Given this list of marker genes CPT2, FGF21, EHHADH, HSD17B4, DECR1, ETFDH, G0S2, ACOT8, ACADM, HMGCS2, DECR2, ALDH3A2, ECI1, CPT1B, CD36, here is a description of the gene set: Hepatic genes regulated by fasting or in response to WY14643 and which require intact PPARA. Human Gene Set: SANDERSON_PPARA_TARGETS studied in species Mus musculus Peroxisome proliferator-activated receptor alpha (PPARalpha) is an important transcription factor in liver that can be activated physiologically by fasting or pharmacologically by using high-affinity synthetic agonists. Here we initially set out to elucidate the similarities in gene induction between Wy14643 and fasting. Numerous genes were commonly regulated in liver between the two treatments, including many classical PPARalpha target genes, such as Aldh3a2 and Cpt2. Remarkably, several genes induced by Wy14643 were upregulated by fasting independently of PPARalpha, including Lpin2 and St3gal5, suggesting involvement of another transcription factor. Using chromatin immunoprecipitation, Lpin2 and St3gal5 were shown to be direct targets of PPARbeta/delta during fasting, whereas Aldh3a2 and Cpt2 were exclusive targets of PPARalpha. Binding of PPARbeta/delta to the Lpin2 and St3gal5 genes followed the plasma free fatty acid (FFA) concentration, consistent with activation of PPARbeta/delta by plasma FFAs. Subsequent experiments using transgenic and knockout mice for Angptl4, a potent stimulant of adipose tissue lipolysis, confirmed the stimulatory effect of plasma FFAs on Lpin2 and St3gal5 expression levels via PPARbeta/delta. In contrast, the data did not support activation of PPARalpha by plasma FFAs. The results identify Lpin2 and St3gal5 as novel PPARbeta/delta target genes and show that upregulation of gene expression by PPARbeta/delta is sensitive to plasma FFA levels. In contrast, this is not the case for PPARalpha, revealing a novel mechanism for functional differentiation between PPARs. from publication Sanderson LM, Degenhardt T, Koppen A, Kalkhoven E, Desvergne B, Müller M, Kersten S (PMID 19805517)